Given this list of marker genes STMN2, MAP1S, TTBK2, AURKB, GAS2L1, CIB1, CKAP2, ATXN7, APC, DIAPH3, MAP6D1, TAOK1, NAV3, BBOF1, SPECC1L, KIF21A, CLASP1, TRPV4, CCDC88C, SPEF1, SPAST, ARHGEF2, TRIM54, KATNB1, BMERB1, MID1IP1, MAP1A, CAMSAP2 (NCBI Gene Id 23271), APC2, HDGFL3, CLASP2, TPX2, GAS2L2, FGF13, MAP1B, WDR47 (WD repeat domain 47), HDAC6, MID1, here is a description of the gene set: Human Gene Set: GOBP_REGULATION_OF_MICROTUBULE_DEPOLYMERIZATION Any process that modulates the frequency, rate or extent of microtubule depolymerization. studied in species Homo sapiens